The following is a description of a gene set: The directed movement of mRNA, messenger ribonucleic acid, into, out of or within a cell, or between cells, by means of some agent such as a transporter or pore. studied in species Mus musculus Mouse Gene Set: GOBP_MRNA_TRANSPORT, and this is the list of marker genes: Chtop, Pabpn1, Nxf1, Alyreffm5, Alyref2 (Aly/REF export factor 2), Ncbp2, Zc3h11a, Alyreffm8, Nup85, Tnks, Tpr, Casc3, 1700017N19Rik, Nup58, Ranbp2, Xpo1, Zfp36, Zc3h3, Ddx19b (NCBI Gene Id 70899), Pcid2, Nxt1, Nup210, Ddx19a, Ncbp1, Srsf3, Nup37, Igf2bp2, G3bp2, Parp11, Ddx25, Hsf1, Nup88, Eif4e, Ranbp17, Nup54, Nup107 (nucleoporin 107), Senp2, Ndc1, Fxr1, Eif4a3, Igf2bp1 (insulin-like growth factor 2 mRNA binding protein 1), Nup43, Thoc5, Bicd2, Sem1, Hnrnpa2b1, Rbm15b, Supt6, Ddx39a (NCBI Gene Id 68278), Nxf7, Thoc7, Alyreffm9, Alyreffm6, Slbp, Igf2bp3, Aaas, Magoh, Alyref, Dhx9, Rbm33, Gle1, Fxr2, Nxf2, Mcm3ap, Alyreffm1, Alyreffm14, Nup160, Hhex, Zfp36l1, Thoc2, Cetn3, Thoc2l, Nup98, Qki, Eny2, Alyreffm11, Nup35, Nup50, Alyreffm10, Lrpprc, Nup93, Nup42, Srsf1, Alyreffm2, Fmr1, Sec13, Nsun2, Hnrnpa3, Magohb, Alyreffm7, Cpeb1, Thoc6, Nup214, Nup188, Ythdc1, Sarnp, Peg10, Fyttd1, Arc, Poldip3, Akap8l, Kif5c, Ncbp3, Iws1, Thoc3, Nxf3, Alyreffm3, Hnrnpa1, Nup155, Thoc1 (THO complex 1), Wnk1, Setd2, Nup62, Pom121, Khsrp, Nxt2, Nutf2 (NCBI Gene Id 68051), Htt, Srsf7, Alyreffm4, Mapt, Ahctf1, Ddx39b, Seh1l, Cetn2, Alkbh5, Rbm8a, Nup133